Given this list of marker genes NR1H2, PLA2G2A, CSF2, MIR130B, ADIPOQ, LPL, PRKCH, IL1B, IL18 (interleukin 18), PF4, CRP, TNF, ITGB3, AGTR1, MSR1, PLA2G5, PLA2G3, SAMD1 (NCBI Gene Id 90378), TGFB1 (NCBI Gene Id 7040), ABCG1, ITGAV, CD36, APOB, ABCA1, NFKBIA, NR1H3, SOAT1, CSF1, PPARG (peroxisome proliferator activated receptor gamma), NFKB1, ALOX15B, PLA2G10, CETP, ABCA5, SOAT2, WNT5A, PPARA, MIR185, MAPK9, AGT (NCBI Gene Id 183), SELENOK, here is a description of the gene set: Human Gene Set: GOBP_FOAM_CELL_DIFFERENTIATION The process in which a relatively unspecialized cell acquires the specialized features of a foam cell. A foam cell is a type of cell containing lipids in small vacuoles and typically seen in atherosclerotic lesions, as well as other conditions. studied in species Homo sapiens